Given this list of marker genes LTA4H, EPN1, C19orf12, HSD3B1, PDLIM1, LUC7L3, FAM89A, PPP1R37, DSP, GIMAP4, GRAMD1A, KIAA0319, GPR88, TRIM46, DMTN, TFAP2A, CLDN3, BTLA, COX7B2, HOXA10, MSRB2, ADCY6, OIT3, GTF2H3, IQGAP2, ZBTB43, ZFHX4, AKAP14, P4HB, KPLCE, SIGLEC1, GALNT16, NUDT11, RPLP0, VASP, FBXL20, SPACA9, PIGY, SPIC, WDR38, ISOC1, IL18BP, DDHD1, TSEN34, CORO1C, IZUMO1R, LRRC58, RASA4, BICC1, FNDC9, CLXN, LCE1A, RB1CC1, RAMP2, LMAN1L (lectin, mannose binding 1 like), HECA, TRIM25, SEC63, GABRA2, SLC7A11, SH3PXD2B, DENND6B, BCORL1, COL18A1, SEMA3D, TMEM245, IKZF1, MZF1, BCO2, RPL3 (ribosomal protein L3), PLEKHH3, ACOX2, ING4, ROPN1 (rhophilin associated tail protein 1), MMP24, PLEKHO2, SKP2, DCC, PRC1, NF1, LGR5, PIK3R5, SLC25A30, SNRNP70, SYT8, NFIB, PGR, SLC43A3, VPS26A, MTO1, IRAK2, DDX46, C2, TGM2, TRMT12, TRIB2, MPP4, ADAM23, EMCN, ITGB1, CCDC126, PALM, BRPF1, NPDC1, ATP1B3, KIAA0513, SRSF6, KIDINS220, PIGG, INPP5K, STXBP2, DGKD, PAH, HMG20A, HSPB9, CDHR2, ATAD3A, CDC14B, ZNF354C, TRPC4AP, NUDT3, TMEM231, CLDN1, PPP2CA, LRRC8C, NBR1, CEACAM20, TPTE, ATXN10, SORT1, DACT3, KLHDC7A, HCN2, NAV1, SCRN1, TSPAN12, C16orf90, MDM1, KLC3, SLC6A13, EGR3, ST6GALNAC1, SNAI3-AS1, BHLHA15 (basic helix-loop-helix family member a15), IP6K1, XIST, PHACTR1, KDM8 (NCBI Gene Id 79831), ABCA9, IRF6, NBEAL1, GNGT1, NDC80, CNN3, OGN, MYOC, MADCAM1, F2RL1, ENTPD4, MACROH2A1, TRIM56, TRAF3IP3, GRM2, PMEL, MARCHF5 (membrane associated ring-CH-type finger 5), USP31, NXF3, LGALS4, STAP2, RAB8A, KCNK12, MMP12, RFX5, TCF7, SEMA6B, FAM91A1, IL4I1, LINGO1, CCDC186, GDF11, SLC5A5, CDH23, C10orf120, SNX32, ATP11B, LIPK, CNOT6, PRM2, CES1, C11orf54 (chromosome 11 open reading frame 54), FAM8A1, N4BP2L2, TCERG1L, HTR4, TTYH3, RENBP, CPNE2, TMEM132E, ZBTB16, SH2D3C, here is a description of the gene set: Human Gene Set: GSE34156_TLR1_TLR2_LIGAND_VS_NOD2_AND_TLR1_TLR2_LIGAND_6H_TREATED_MONOCYTE_UP from publication Schenk M, Krutzik SR, Sieling PA, Lee DJ, Teles RM, Ochoa MT, Komisopoulou E, Sarno EN, Rea TH, Graeber TG, Kim S, Cheng G, Modlin RL (PMID 22447076) species: Homo sapiens human blood monocytes were isolated, activated and harvested at several timepoints In this study, we identified genes that were differentially expressed in human monocytes activated with eiter NOD2L and/or TLR2/1L. Genes up-regulated in monocytes (6h): M. tuberculosis 19 kDa lipopeptide versus M. tuberculosis 19 kDa lipopeptide and muramyl dipeptide.